The following is a description of a gene set: Genes regulated in MCF7 cells (breast cancer) by expression of the truncated (611-CTF) form of ERBB2 at both 15 h and 60 h time points. HER2 is a tyrosine kinase receptor causally involved in cancer. A subgroup of breast cancer patients with particularly poor clinical outcomes expresses a heterogeneous collection of HER2 carboxy-terminal fragments (CTFs). However, since the CTFs lack the extracellular domain that drives dimerization and subsequent activation of full-length HER2, they are in principle expected to be inactive. Here we show that at low expression levels one of these fragments, 611-CTF, activated multiple signaling pathways because of its unanticipated ability to constitutively homodimerize. A transcriptomic analysis revealed that 611-CTF specifically controlled the expression of genes that we found to be correlated with poor prognosis in breast cancer. Among the 611-CTF-regulated genes were several that have previously been linked to metastasis, including those for MET, EPHA2, matrix metalloproteinase 1, interleukin 11, angiopoietin-like 4, and different integrins. It is thought that transgenic mice overexpressing HER2 in the mammary glands develop tumors only after acquisition of activating mutations in the transgene. In contrast, we show that expression of 611-CTF led to development of aggressive and invasive mammary tumors without the need for mutations. These results demonstrate that 611-CTF is a potent oncogene capable of promoting mammary tumor progression and metastasis. from publication Pedersen K, Angelini PD, Laos S, Bach-Faig A, Cunningham MP, Ferrer-Ramón C, Luque-García A, García-Castillo J, Parra-Palau JL, Scaltriti M, Ramón y Cajal S, Baselga J, Arribas J (PMID 19364815) Human Gene Set: PEDERSEN_METASTASIS_BY_ERBB2_ISOFORM_3 species: Homo sapiens, and this is the list of marker genes: NABP1, CLEC18C, LMO7, TFPI2, MIR22HG, ZNF697, EGFR, PKP2, MIR21, STARD4, ENC1, CLCF1, NPY1R, F2RL1, NPC1, VMP1, TNFAIP8, CPEB4, RGS2, PRR15L